Given this list of marker genes BICRA, POLR2J2, ATP6V0A1, CIDEB, GNG7, VIPR1, ITFG2, ITGAX, SPTAN1, ADAP1, HGS, NLRP1, KHNYN, HEXD, AP1G2, AKAP17A, NME3, MKNK2, IL18BP, COMT, PEMT, TRRAP, VPS16, IL18, KDELR1 (KDEL endoplasmic reticulum protein retention receptor 1), SYVN1, RARA, CERK, TGOLN2, SPOCK2 (SPARC (osteonectin), cwcv and kazal like domains proteoglycan 2), SMARCD1, SGSM2, SLC16A5, RAB12, FAM156B, NAA16, PIAS4, CD300C, TPCN2, CDC42EP3, CXorf65, P4HTM, ECHDC2, PSMD12, HLA-DRB4, RSRP1, LTBP4, TP53I13, FUBP3 (far upstream element binding protein 3), HLA-DQA1, TCIRG1, MBD1, ATXN1L, NR2C1, QPCT, PRXL2A, PLA2G4B, ADAM19, ZNF786, UVRAG, C9orf72, ZFHX3, MMP23B, PI4KAP2, NADSYN1, NOL12, ADHFE1, VPS52, MCOLN2, AP3D1, AMY2A, RHOG, AAK1, SUGP1, KIAA0930, WDR59, TNFRSF1B, ASCC2, CSNK1E, FGD3, STX4, PATL2, GAS7 (NCBI Gene Id 8522), ZNF223 (NCBI Gene Id 7766), ZNF493, ASPSCR1, TUBGCP5, RAX2, NPIPA1, CYC1, ZNF503, SLC26A6, PRKY, APOBR, PABPC1L, TOP3B, MFSD3, RBM33, ZNF598, RAD54L2, TINF2, GIT2, SUSD6, YJU2B, INTS3, CCL3 (C-C motif chemokine ligand 3), BTN2A1, PLCXD1, CNNM3, PPP1CA, CSAD, ATG4B, PCED1B, CLCN6, CLEC7A, TSPAN32 (NCBI Gene Id 10077), RABL2B, SULT1A1, RELCH, ZBTB40, RUSC1, SCO2, CES2, HLA-DRB1, GMDS, EIF4E2, TCEA2, GPS1, ADGRG1, ZDHHC8, RIPOR2, MOB3A, P2RX7, ERAL1, TUBG2, MAU2, CREBBP, BTN3A1, DIDO1, C6orf136, GGA3, TCAF1, SMG5, ENGASE, NAGPA, WDR73, E2F4, LILRB3, DEF8, SNX1, UBXN11, KRBA1, NCLN, PHF19, GJC1, IFITM2, FKBP15, TAF6L, SSH3, PNPLA6, ADAM15, HES4, LAG3, SEC14L1, SAFB2, GAL3ST4, RNF216, OTULINL (OTU deubiquitinase with linear linkage specificity like), LRRC14, EIF1, METTL3 (NCBI Gene Id 95719), ANKRD36B, ZC3H3, MOGS, TMEM175, STK40, UPK3BL1, VPS9D1, SNX27, CEP131, USP4, TNFRSF14, SLCO3A1, RUSF1, COPE, DNAH1, COQ10A, GPR137, NBPF14, IL2RB, RNF115, TRPC4AP, LRP10, ITGA5, MAP7D1, NKTR, PPP1R35, PLAGL1, PLSCR3, STAG3L1, KCNMB1, ANKS1A, ENO3, ATP6AP1, AP4B1, JARID2, POLM (NCBI Gene Id 27434), NSUN5, GPR162, POLR2J3, ACAD11, CCR6, PI4KAP1 (NCBI Gene Id 728233), TLR6, GMIP, GON4L, TMEM179B, MYO18A, ZNF548, ZFYVE26, HELZ2, SHFL, ARK2C, MPEG1, PRSS53, FES, PDE4C, SLC12A9, SLC25A42, GRAMD4, PRKCSH, S100Z, STAT6, CASP8, FARSB, B4GALT5, IRF1, ABHD18, MBD6, PRKCD, PRDX2, ADISSP, FRS3, NLRP2, KDM5D, CBLB, SBF1, FCER1G, CXCL16, ANKDD1A, SEC24C, CHKB, DUS3L, TMEM176A (transmembrane protein 176A), SHCBP1, ZC3H12A, PIGT, TMEM138, NOL6, PCNT, RASGRP4, MTCH1, KIF21B, FBP1, ARHGAP33, IRF7 (interferon regulatory factor 7), CWC25, SF3B1, SF3B4, OSBPL7, AHR, EPN1, ABR, CBX6, PPTC7, KRT73, ANKRD36, RNF126 (NCBI Gene Id 55658), SLC2A3, NPRL3, SPG21, ARRDC5, VASH1, PDPR, MCM8, BRAT1, GSTK1, NLRC5, IL10RA, ABHD3, ZNF362, PTCD1, WAS, WDR54, NCF1, TRPT1, UCKL1, CYBA, GSE1, HSH2D, TNF, DVL3, TNK2, CYTH1, MYOF (NCBI Gene Id 26509), ZNF746 (zinc finger protein 746), IDH3G, ZNF346, CLSTN1, MAP3K8 (mitogen-activated protein kinase kinase kinase 8), CLN3, KLF13 (KLF transcription factor 13), NBPF11, ACSS2, SPI1, ANKRD11, CDKN1C, COX19, ZFP36L2, SLC16A12, TNFRSF25, SREBF1, RBM14, MIIP, CRTAP, RALGPS1, TNFSF12, BRD9, DNMT1, SULT1A2, CRCP, ANXA11, CTC1, CAT, PPP1R15A, CSNK1D, PFKL (phosphofructokinase, liver type), NFIC, ACVR1B, SLC25A28, ZDHHC1, IL11RA, BCL3, DGKQ, NINJ1, PRR14, AGAP4 (NCBI Gene Id 728404), DYSF, DNAJC28, EMD, REC8 (NCBI Gene Id 9985), D2HGDH, GARRE1, ELMO2, LINC00954, HERPUD1, GSTM1, ARAF, PFKFB3, SEPTIN9, ARHGAP4, ARID3B, SPNS1, GTPBP3, SCAP, SPHK2 (sphingosine kinase 2), MZF1, CPSF1, FGR, ETV3, MARCHF1, CLIP4, CD74, ZYX, LILRB1, SYNJ2BP, IL18RAP, CLDN15 (claudin 15), ACADVL, SLC26A11, MX1, SLC22A18, TAGLN, NDUFV1, MCM3AP, TUBGCP6, PABPC1, REXO1, HINT3, ULK1, NMRAL1, HSPA7, LPIN1, SERPINA1, ARHGAP27, KLF6, CMIP, TTC31, ALDOA, CLK3, TOM1, SCPEP1 (serine carboxypeptidase 1), RENBP, MAPK8IP3, SPATA20, LSS, UNK, BRI3, SEPTIN7P2, TRABD (TraB domain containing), ZMIZ1, SLC3A2, ALAD, HK3, AKAP13 (A-kinase anchoring protein 13), RHOT2, MEF2D (myocyte enhancer factor 2D), CDK5RAP3, SKIC2, CNDP2, CEBPB, PLAUR, MNT, INIP, TMEM131, SEC22C, METTL17, ZNF296, MYO9B, STAG3L3, PSTPIP1, ROCK2, IRF4, NCF4, ADCY7, PHACTR4, HCFC1, POLG, ZBTB48, NIBAN2, CLEC16A, LZTR1, IQSEC1, NPEPL1, VSIR, EFHD2, IKBKG, BTBD2, N4BP1, SPSB3, CUEDC1, MUTYH, GPS2, S100A10, ADGRE5, RDH5, MAN2C1, PLCH2, KLHL3, FAM156A, CDK11B, KAT2A, PNPT1, HPS4, CDAN1, QTRT2, NRROS, LUC7L, MAN2A2, IQCN, CYTH2, DENND1C, NAGK, NUCB1 (NCBI Gene Id 4924), SLC2A9, TICAM1, PILRB, ZZEF1, DHRS1, EBLN2, ZSCAN18, BHLHE40, SPEN, CD1C, ARL17A, NCSTN, FCN1, CIMAP1B, CELF2, PATJ, PLAGL2, KATNIP, RASAL3 (NCBI Gene Id 64926), H3-5, SETDB1, STAG3L2, WRAP73, PCSK7, GRAMD1A, RAB24, TCF25, TEPSIN (NCBI Gene Id 146705), WDFY2, YJU2, SLFN13, IER5, JAK1, SLC27A3, DICER1, SNORA67, TMEM164, PTPRE, GOLGA8B, TPM2, SMAP2 (small ArfGAP2), CACNA1I, ARL16, HLA-DMA, SUGP2, GRK2, ENTPD4, SNORD4A, ALKBH6 (NCBI Gene Id 84964), NOP2, NUP62, CARD9, FAAP100, IP6K1, ARRDC3, HAUS2, ATP13A1, NECAP1 (NCBI Gene Id 25977), RAB40C, USP32 (ubiquitin specific peptidase 32), ZNF573, IMPDH1, ATG2A, LRSAM1, CHFR, NDE1, NRBP2, ZNF669, HCG27, CSF3R, RAB27A, PDXDC1, CENATAC, ITGAL (integrin subunit alpha L), PLEKHM2, RAP1GAP2, IDUA, THOC6, MICAL1, GRN, NFATC2IP, BMAL1, PARP10, ENG, PIGQ, TRAPPC14, GMEB2, EXOSC10, FN3KRP, SNORD35B, LYN, TAF1C, U2AF1L4 (U2 small nuclear RNA auxiliary factor 1 like 4), ICA1, FBXL6, TRIM8, FLII, ARFGAP2, SLC2A8, SMPDL3A, PLD3, KCTD13, LRP5L, CD33, HPS1, PLXNB2, YPEL2, AGAP6, CSF2RA, GAB2, CD302, PILRA, KXD1, WDR6, CTRL, APBB3, SLC25A22, NBPF3, PITPNM1, LILRA3, TXNRD2, OCEL1, STRIP2, PIK3R2, CPNE1, SNORA61, LYZ, TOGARAM2, ALG9, STRADA, CSNK1G2, MAP4K1, TUT4, GAK (cyclin G associated kinase), FUT4, ALDH2, RHBDF2, PSMC4, CFL1, MKNK1, SNORD10, TNFRSF10B, PRAM1, INTS1, BCKDK (branched chain keto acid dehydrogenase kinase), JMJD8, CMTM7, PLSCR1, HIC2, TJAP1, NXF1, POFUT2, AMT, NAPRT, EML3, DIP2A, GSTM2, STX16, ASAH1, TRMT1, EP300, PRKRIP1, IKBKB, AP1M1, TYK2, CYB561, IRF9, HNRNPM, SLC44A4, ANKMY1, TM9SF4, CNN2, EVL, PAN2, NDST2, DPAGT1 (NCBI Gene Id 1799), TMEM150A, CCNL1, RIPOR1, COTL1, FKTN, LTO1, WDR37, CLDND2, RNF44, GABPB2, SLC11A1, CSF1R, NSUN5P1, APOL3, QSOX2, IFFO1, ZNF827, TRAF1, NBPF10, DDX56, RBM23, AKT1 (AKT serine/threonine kinase 1), FBXW9, SUN1, SF1, PAXX, SLC7A6, DUS1L (NCBI Gene Id 64118), CARM1, MED25, CASZ1, NISCH, MED16, ARL17B, RNASEH1, IFI44L, SULT1A3, KIF22, ITPR3, DNASE1L1, MIDEAS, SMARCC2, ORC6, TMEM131L, TNNI2, DOCK2, EIF4H, ALOX5, E4F1, PSAP, ZNF839, KIR2DL3, GALT, KRT72, ZNF430, CHN2, PPOX, S100A11, SRSF2, INTS4, SRSF4, SND1-IT1, DGLUCY, GFOD1, CARNS1, TRIM22, CREBZF, MYADM, OXA1L, FCGRT, DOP1B, ITGB2, C15orf39, ZNF467, KDM2A, CDC37, FRAT2, PLEKHM1, UBA7 (ubiquitin like modifier activating enzyme 7), ANKRD30B, CFD, PIEZO1, DMAP1 (NCBI Gene Id 55929), TMEM259, CDH23, DNAAF5, RPL10, ADA2, ZNF513, MAN2B1, DAGLB, RUNX3, OCIAD1, CDC42EP4, AIRE (autoimmune regulator), TTLL3, LPCAT3, CCM2, PNMA3, GHDC, MCM7, PPP1R18, STAT2, CFAP418 (NCBI Gene Id 157657), USP3, MXD1 (MAX dimerization protein 1), PCED1A, ZMYND15, ARHGAP1, ZNF526, TYROBP, FCGR2A, ZFP36, RAF1, TRIM44, MAN1B1, PBX4, STING1 (stimulator of interferon response cGAMP interactor 1), CEP192, PI4KA, MXD4, KIAA0319L, CDK10, S100A4, SNORD36C, SLC15A3, SPG7, ZXDC, POLR1C, AXIN1, FXYD5, CSGALNACT2, FTL, TRIM66 (NCBI Gene Id 9866), ITIH4, COX8A, MAST3, SULT1A4, IL10, ZNF486 (NCBI Gene Id 90649), GUSB, CAPS, REPIN1, CLCN7 (chloride voltage-gated channel 7), MIDN, FOXJ2 (forkhead box J2), SIK3, ATP2A2, UNC119, EHBP1L1, PGS1, C11orf21, MILR1, CDK5RAP1, GSDMB, TBC1D2, NSUN5P2, RAB11FIP1, SCNM1, NPIPB15, SLC4A5 (solute carrier family 4 member 5), MNDA, COPS7B, CYTH4, LILRA6, LRCH4, MDC1, ENTPD6, CXXC1, SH3GLB2, KLF10, DGKA, TBC1D3G, WASHC1, C2orf69, ITIH5, HNMT, PLCB2, ELF4, PGAM1, HOXB2, DUSP18, NDUFB4, KATNB1, CUX1, SRRM2, RBCK1, ZNF142, PGAP3, STK36, AKR1D1, RNFT1, STK25, DLL1, DAPP1, USP36, VAMP1, BCS1L, C1orf162, QRICH1, CMTM4, CACNA2D4, TOP3A, CST3, SNX29, ZMIZ2, SDE2 (SDE2 telomere maintenance homolog), ZNF674, STK10, EPM2AIP1, UBR4, SRRT, CDK9, PPP1R12C, NOTCH1, RPL7L1, MFSD10, DENND6B, CTSB, RANBP3, RAI1, SMCR5, NSMF, RNASET2, MBD2, XPO6, LMTK3, ADAM8, GTPBP6, ACCS, SNRNP70, SMARCA4, WWP2, PARVG, TTF2, MEGF6 (NCBI Gene Id 1953), ZNF275, MAEA, SLC8B1, NUAK2, ABL1, WASH3P, DPEP2, RAPGEF1, IFITM3, TRIM5, PPP1R3E, UTRN, DENND3, PNISR, MMS19, CREB1, LST1, FNIP1, C21orf58, here is a description of the gene set: studied in species Homo sapiens Human Gene Set: THAKAR_PBMC_INACTIVATED_INFLUENZA_AGE_21_30YO_RESPONDERS_28DY_DN To elucidate gene expression pathways underlying age-associated impairment in influenza vaccine response, we screened young (age 21-30) and older (age >= 65) adults receiving influenza vaccine in two consecutive seasons and identified those with strong or absent response to vaccine, including a subset of older adults meeting criteria for frailty. PBMCs obtained prior to vaccination (Day 0) and at day 2 or 4, day 7 and day 28 post-vaccine were subjected to gene expression microarray analysis. We defined a response signature and also detected induction of a type I interferon response at day 2 and a plasma cell signature at day 7 post-vaccine in young responders. The response signature was dysregulated in older adults, with the plasma cell signature induced at day 2, and was never induced in frail subjects (who were all non-responders). We also identified a mitochondrial signature in young vaccine responders containing genes mediating mitochondrial biogenesis and oxidative phosphorylation that was consistent in two different vaccine seasons and verified by analyses of mitochondrial content and protein expression. These results represent the first genome-wide transcriptional profiling analysis of age-associated dynamics following influenza vaccination, and implicate changes in mitochondrial biogenesis and function as a critical factor in human vaccine responsiveness. from publication Thakar J, Mohanty S, West AP, Joshi SR, Ueda I, Wilson J, Meng H, Blevins TP, Tsang S, Trentalange M, Siconolfi B, Park K, Gill TM, Belshe RB, Kaech SM, Shadel GS, Kleinstein SH, Shaw AC (PMID 25596819) Genes down-regulated in peripheral blood mononuclear cell 28d vs 0d in young adults (21-30) (responders) after exposure to Inactivated influenza vaccine, time point 28D